Given this list of marker genes G, N, HSP90AB1, M2-1, F, Human respiratory syncytial virus A2, complete genome, SH, L, M, P, HSP90AA1, here is a description of the gene set: part of: Respiratory Syncytial Virus Infection Pathway A mature virion of the respiratory syncytial virus (RSV) consists of the ribonucleoprotein complex (RNP) surrounded by the protein matrix and a lipid bilayer envelope. The RNP is composed of the genomic negative sense single-stranded (-ssRNA) that is tightly associated with the N protein (nucleoprotein) and the RNA-dependent RNA polymerase complex (RdRP). The RdRP consists of the L protein subunit (large polymerase subunit), the P protein subunit (phosphoprotein polymerase cofactor), and the M2-1 protein, which acts as a transcription processivity factor. The matrix consists of the M (matrix) protein. The M2-1 protein serves as the bridge between the RNP and the M protein. The matrix supports the viral envelope. The viral envelope contains three embedded viral proteins: fusion protein (F), attachment protein (G), and a small hydrophobic protein (SH). The M protein associates with the cytoplasmic domain of the F protein. The SH protein forms a pentameric ion channel in the viral envelope and is thought to delay apoptosis of infected cells. The assembly and budding of RSV virions primarily occurs at the apical surface of ciliated airway epithelial cells where viral filaments containing RNPs form. The budding of RSV virions requires interactions between viral proteins, host cytoskeletal proteins, and membrane. For review, please refer to Shaikh and Crowe 2013, and Battles and McLellan 2019.<br><br>Based on the findings that P, M, and F proteins are sufficient for formation of viral‑like particles (VLPs), P protein, particularly its highly phosphorylated serine/threonine‑rich region between amino acids 39 and 57 that likely interacts with M and/or F proteins, may play an important role in the assembly. Reactome Pathway: Assembly and release of respiratory syncytial virus (RSV) virions studied in species Homo sapiens